The following is a description of a gene set: This event has been computationally inferred from an event that has been demonstrated in another species.<p>The inference is based on the homology mapping from PANTHER. Briefly, reactions for which all involved PhysicalEntities (in input, output and catalyst) have a mapped orthologue/paralogue (for complexes at least 75% of components must have a mapping) are inferred to the other species. part of: Nucleosome assembly studied in species Mus musculus Reactome Pathway: Deposition of new CENPA-containing nucleosomes at the centromere electronically inferred by orthology from the curated human pathway, and this is the list of marker genes: H2ac4, H4c4, H2ax, H4c6, H2ac1, H2bc8, H2bc11, Oip5, Rbbp7, H2ac6 (NCBI Gene Id 319164), H2bc13, H4c2, H2az2, H4c9, H4c12, H4c8, H4c3, H2bc27, H2ac12, H2bc1, Cenpu, Npm1, H4c11, Smarca5, H4c1, Cenps, H4c17, H2ac7, H4c18, H2bc12, H2ac10, H2ac15, H4c14, H2bc9, Cenpn, Cenpq, Cenpx, H2bc22, Cenpa, Hjurp (NCBI Gene Id 381280), H2bc15, H2ac11, H2ac19, H2bc3, H2ac20, H2ac22, H2ac8, H2bc7, Cenpt, Rbbp4, Itgb3bp, H2ac24, Cenpm, H2ac13, H2ac23